The following is a description of a gene set: studied in species Mus musculus Mouse Gene Set: GOCC_TELOMERASE_HOLOENZYME_COMPLEX Telomerase is a ribonucleoprotein enzyme complex, with a minimal catalytic core composed of a catalytic reverse transcriptase subunit and an RNA subunit that provides the template for telomeric DNA addition. In vivo, the holoenzyme complex often contains additional subunits., and this is the list of marker genes: Lsm11, Smg5, Snrpb, Hnrnpc, Snrpe, Nvl, Nat10, Hnrnpu, Acd, Gnl3l, Snrpert, Smg6, Ptges3, Nop10, Tep1, Ptges3-ps, Nhp2, Gar1, Tert, Smg7, Snrpd3, Dkc1, Wrap53